The following is a description of a gene set: Genes up-regulated in comparison of IgD+ B cells versus IgD- B cells. studied in species Homo sapiens Human Gene Set: GSE12845_IGD_POS_VS_NEG_BLOOD_BCELL_UP B cells from human tonsil and blood were sorted using flow cytometry. The human samples were processed immediately ex-vivo using markers for known B cell subsets. from publication Longo NS, Lugar PL, Yavuz S, Zhang W, Krijger PH, Russ DE, Jima DD, Dave SS, Grammer AC, Lipsky PE (PMID 19023113), and this is the list of marker genes: KDM4D, MBNL1, CD22, FAM120C, CROCCP3, RPL23AP53, CEMIP2, KMO, CNTRL, TPT1, TCN2, ANKZF1, VTN, ZFHX2, MUTYH, DBH, P2RY14, LDOC1, AMT (NCBI Gene Id 275), B3GAT3, MMD, PENK, CNTN2, SATB1, FCHO1, JUNB, ZNF767P, ELP6, NPFFR1, BCL6, CPS1, H1-2, PLEKHA1, H2BC9, BCL7A, FCER2, NEURL1 (neuralized E3 ubiquitin protein ligase 1), PAIP2B, H4C11, C1QTNF1, TNFSF14, ZNF516, GUCY2F (guanylate cyclase 2F, retinal), KIF25-AS1, SPTLC2, ICOSLG, ECEL1, HMCES, TRIB2, ZNF135, TNNC1, TREML2, PPM1F, PKNOX1, DDX31, INO80D (INO80 complex subunit D), TMEM161A, SESN1, HTT, RPS23, SKAP1, ZNF266, OR2H1, IGSF1, BST1, CNTNAP2 (contactin associated protein 2), UXS1, EPB41L2, CD79A, CD19, STEAP1B, APLP2, ZNF428, ATP10D, SH3BP2, SLA, DDX5, ICOS, PDP1, TTC9, KLRK1, PHACTR1 (phosphatase and actin regulator 1), LRCH4, DCAF1, PAN2, MED12, RAMP1, GUCY2D, DCHS1, TSSC4, MIR622, DENND4B, RANBP10, ARSF, IL17B, SIGLEC7, DHX16, RASA2, GIMAP5, ITGA5, HK3, ORAI3, PCDH9, POLDIP3, PHF1, CLEC4A, YBX3, SF1, ZNF324, MTMR2, CCL27, GALNS, SLC4A5, MAPK8IP3, DGKD, NSMF, HDAC5, CD28, MMP17, ADARB1, LGALS9, ZNF334, ADCY1, ARHGAP22, NAT10, KIAA0040, PPFIBP1, ALOXE3, POLH, TENT5A, PIK3C2B, HPS1, PHLPP1, AP1G2, PLCG1, LIMS2, EML3, TNFSF13, SLC9A8, AGPAT2, TBC1D1 (TBC1 domain family member 1), TCL6, ZNF692, DDX27, TPST1, PILRB, SIAH2, CRTC3, AMACR, POMT2, HLA-DRA, CUL7, NUDCD3, H2BC12L, ZNF592, PIP4K2B, RAB20, H2AC6 (H2A clustered histone 6), IL4R, MPRIP, PHC1, RPS27, RNF220, PRSS3, B3GNT4, H2BC21, POLL, CDK10, CBLC, SCRN3, UBASH3A, SCN5A (sodium voltage-gated channel alpha subunit 5), SYT17, SRRM2, RGL2, SARAF, ANPEP, DTX4, CD40, NCK2, EVL, NXF1, H2BC6, ZNF415, IDH3B, TFAP2B, WASF1, NLRP1, CD2, BICDL1 (NCBI Gene Id 92558), AGO4, CDHR5, ADGRF1, PACS2, H2BC8 (H2B clustered histone 8), IGHV5-78, H2BC7 (NCBI Gene Id 8343), SORL1, FLOT2